The following is a description of a gene set: Neighborhood of TTN Neighborhood of TTN titin in the GNF2 expression compendium Human Gene Set: GNF2_TTN species: Homo sapiens, and this is the list of marker genes: TNNI2, MYOZ1, TPM3, MYH1 (myosin heavy chain 1), TTN, ANKRD2, MYL1, LDB3, MYBPC2, ATP2A1 (NCBI Gene Id 487), MYBPC1, TNNI1, ENO3, TNNT3, TNNT1, KLHL41, TNNC2, CASQ1, PYGM, MYH2, RYR1, MYOT, NEB, ACTN3, CKM, SLN